The following is a description of a gene set: studied in species Homo sapiens Human Gene Set: REACTOME_RNA_POLYMERASE_I_TRANSCRIPTION RNA Polymerase I Transcription, and this is the list of marker genes: H2BC6, H2AB1, H4C9, H3C2, CHD3, GATAD2A, POLR1C, H2AC8, POLR1G, GTF2H2, POLR2H, H3C10, H2BC21 (H2B clustered histone 21), TTF1, POLR2L, MBD2, H3C13, H2AJ, POLR1H, POLR1F, H3C7, MBD3, H4C13, H3-3A, H2BC9, H4C11, H4C5, GTF2H5, EHMT2, TAF1B, TAF1D, H2BC3, TAF1C, ERCC3, POLR1B, H2BC11, H4C12 (H4 clustered histone 12), POLR1E, H2AC14, GATAD2B, CDK7, TAF1A, GTF2H4, RBBP4, CBX3, H3-3B, HDAC1, CHD4, H2BC15, KAT2B, CAVIN1, H3C6, HDAC2, H2AC4, POLR2K, H2AC6, MTA2 (NCBI Gene Id 9219), H4C4, H4C15, H2BC26, H4C1, H2AX, H2AZ2, H4C6, H3C12, H2BC10, H2BC12, MAPK3, H2AC18, H4C3, ERCC2, H4C8, H3C8, H3C1 (NCBI Gene Id 8350), GTF2H3, H2BC1, H3C11, MNAT1, UBTF, H3C15, H2BC13, KAT2A (NCBI Gene Id 2648), H2BC5, ERCC6, MTA3, POLR1D, RBBP7, POLR2E, H2BC14, CCNH, H2BC8, POLR2F, H2BC12L, H3C3, MTA1, H4C16, H2AC19, RRN3, H2AC20, H2BC17, H3C4, H4C14, H2BC7, GTF2H1, H2AC7, H3C14, TBP, H2BC4, H4C2, POLR1A